The following is a description of a gene set: Reactome Pathway: p75 NTR receptor-mediated signalling studied in species Homo sapiens part of: Death Receptor Signaling Besides signalling through the tyrosine kinase receptors TRK A, B, and C, the mature neurotrophins NGF, BDNF, and NT3/4 signal through their common receptor p75NTR. NGF binding to p75NTR activates a number of downstream signalling events controlling survival, death, proliferation, and axonogenesis, according to the cellular context. p75NTR is devoid of enzymatic activity, and signals by recruiting other proteins to its own intracellular domain. p75 interacting proteins include NRIF, TRAF2, 4, and 6, NRAGE, necdin, SC1, NADE, RhoA, Rac, ARMS, RIP2, FAP and PLAIDD. Here we annotate only the proteins for which a clear involvement in p75NTR signalling was demonstrated.<br>A peculiarity of p75NTR is the ability to bind the pro-neurotrophins proNGF and proBDNF. Proneurotrophins do not associate with TRK receptors, whereas they efficiently signal cell death by apoptosis through p75NTR. The biological action of neurotrophins is thus regulated by proteolytic cleavage, with proforms preferentially activating p75NTR, mediating apoptosis, and mature forms activating TRK receptors, to promote survival. Moreover, the two receptors are utilised to differentially modulate neuronal plasticity. For instance, proBDNF-p75NTR signalling facilitates LTD, long term depression, in the hippocampus (Woo NH, et al, 2005), while BDNF-TRKB signalling promotes LTP (long term potentiation). Many biological observations indicate a functional interaction between p75NTR and TRKA signaling pathways. <br>, and this is the list of marker genes: NET1, ARHGEF38, ITGB3BP, APH1A, ARHGEF12, VAV3, HDAC3, PSEN2, RTN4, ARHGEF9, ECT2, RIPK2, FGD2, IKBKB, NGF, CASP3, KALRN, SQSTM1, BAD, NCSTN, OMG, ARHGEF5, ARHGEF33, NGFR, IRAK1, AKAP13, YWHAE, HDAC1, FGD3, MAGED1, ARHGEF39, APH1B, MAG, ARHGEF10L, NGEF, CASP2, ARHGEF6, FGD1, MAPK8, PLEKHG5, ARHGEF40, UBA52, MCF2, TRAF6, ARHGEF35, UBC, PSEN1, RAC1, BCL2L11, ABR, ARHGEF7, RHOA, TIAM1, ARHGEF26 (NCBI Gene Id 26084), ADAM17, ARHGEF2, FGD4, ARHGEF16, PRKCI, ITSN1, VAV2, ARHGEF19, PLEKHG2, TRIO, UBB, LINGO1, ARHGEF3, PRDM4, ARHGEF11, RELA, ARHGEF15, ARHGEF37, HDAC2, RPS27A, ARHGEF10, ARHGEF18, ARHGDIA, ARHGEF17, PSENEN, AATF, SORCS3, MYD88, VAV1, MCF2L, PREX1, ARHGEF4, GNA13, NFKBIA, SMPD2, SOS2, TIAM2, ARHGEF1, RASGRF2, NFKB1, OBSCN, BEX3, RTN4R, SOS1